Given this list of marker genes Dcaf1, Ddb2, Wdr77, Dda1, Ambra1, Dcaf13, Dcaf8l, Dcaf5, Fbxw5, Cop1, Arih1, Dcaf12, Ercc8, Det1, Cul4a, Dcaf12l2, Trim63, Dcaf10, Crbn, Rbx1, Dcaf11, Dcaf17, Dcaf7, Dcaf12l1, Dcaf15, Trpc4ap, Ddb1, Cul4b, Rbx1-ps, Glmn, Wdtc1, Dcaf4, Dcaf8 (DDB1 and CUL4 associated factor 8), Dcaf6, Dtl, Cdkn1b, here is a description of the gene set: studied in species Mus musculus A ubiquitin ligase complex in which a cullin from the Cul4 family and a RING domain protein form the catalytic core; substrate specificity is conferred by an adaptor protein. Mouse Gene Set: GOCC_CUL4_RING_E3_UBIQUITIN_LIGASE_COMPLEX